The following is a description of a gene set: studied in species Homo sapiens Estrogen-dependent gene expression Human Gene Set: REACTOME_ESTROGEN_DEPENDENT_GENE_EXPRESSION, and this is the list of marker genes: MOV10, SMC3, TBP, H2AX, H3-3A, FOS, H2BC15 (NCBI Gene Id 8341), CCNT1, EBAG9, BCL2, H2AZ2, KCTD6, CBFB, TFF1, FOXA1, CTSD, POLR2D, HSP90AB1 (NCBI Gene Id 3326), H4C3, POLR2C, NCOA3, RAD21, CITED1, H2BC5, POLR2E, H3C6, H2BC3, H4C8, CCND1 (cyclin D1), POLR2G, POLR2H (NCBI Gene Id 5437), H3C7, PTGES3, H2BC4, AGO2, FKBP4, ATF2, AXIN1, KDM1A, AGO1, H2BC26, H4C9, H2BC6, H2BC11, NCOA2, H3C14, CREBBP, FOSB, H2AC19, H2AC20, NCOA1, H2BC7, KAT5, AGO4, TNRC6A, SP1, POU2F1, H2AC8, H2AC14, HSP90AA1, H3C4, H3C3, GATA3, MYC, H2BC12, H2AJ, MED1, CXXC5, TLE3, H4C15, H2BC10, GTF2A2, H3C10, GPAM, H4C4, H4C2, KDM4B, H2AB1, EP300, JUN, ERBB4, H2BC8, H2BC9, CARM1, H3C11 (NCBI Gene Id 8354), H3C13, CDK9, SMC1A, H4C11, GTF2F1, ESR1, NR5A2, PGR, NRIP1, H2BC17, CHD1, GREB1, POLR2K, USF2, H2BC21, PRMT1, H4C1, HDAC1, TNRC6B, STAG1, TGFA, H2BC13, JUND, H4C16, TNRC6C (trinucleotide repeat containing adaptor 6C), USF1, KPNA2, KANK1, H2AC18, RUNX1, H4C14, DDX5 (DEAD-box helicase 5), KAT2B, H2BC1, POLR2J, GTF2F2, TFF3, POLR2B, H3C8, H2BC12L, YY1, H4C5, ZNF217, H2AC4, H3-3B, MYB (NCBI Gene Id 4602), POLR2F (NCBI Gene Id 5435), STAG2, H4C6, H2AC7, POLR2A, CXCL12, H3C15, H4C12, H2BC14, H3C2, H3C12, POLR2L, H3C1, POLR2I, H2AC6, H4C13, GTF2A1, AGO3